Given this list of marker genes EMILIN2, PLPP3, TNFSF11, IL6ST, IL6R, CTSG, CCL5 (C-C motif chemokine ligand 5), EMILIN1, CTNNB1, IL6, MMRN1, PLAUR, PDPN, JAK2, JAK1, F11R, HTR2A, ANK3, MFSD2B, GP6 (glycoprotein VI platelet), here is a description of the gene set: species: Homo sapiens Any process that activates or increases the frequency, rate, or extent of homotypic cell-cell adhesion. Human Gene Set: GOBP_POSITIVE_REGULATION_OF_HOMOTYPIC_CELL_CELL_ADHESION